Given this list of marker genes RPL15, RPS27, RPL30, MRPL19, RPS3, RPS15, RPS19, RPL4, RPL7, RPL23A, RPL14, RPS9, UBA52, RPS12, RPL38, RPS27A, RPS6KA1, RPS11, RPS10, RPL39, RPS14, RPSA, RPS21, RPS25, RPL18A, RPL29, RPL3, RPL27, RPL36 (NCBI Gene Id 92364), RPS15A, RPL13, RPL21, RPL13A, RPL23, RPS6KA2, RPS6KA6, RPS6, RPS26 (NCBI Gene Id 6231), RPL41, RPL10 (ribosomal protein L10), RPS23, RPL34, RPL12, RPS6KB2, RPL35A, RPLP0, RPS13, RPS29, RPL28, RPS4X, RPS4Y1 (ribosomal protein S4 Y-linked 1), RPS20, RPL11, RPL7A, RPL22, RPL37A, RPL37, RPL27A, RPS6KA3, RPL5, RPL9, RPS16, RPL10A, RPS8, RPL6 (NCBI Gene Id 6128), RPS5, RPL19, RPS6KB1, RPL3L, RPLP2, RPL31, RPL32, RPL24, RPS17, RPL8, FAU, RPS2, RPL36A, RPL17, RPS18, RPS24, RPS3A (NCBI Gene Id 6189), RPL35, RPS7, RPL18, RPL26, RPLP1, RPS28, here is a description of the gene set: studied in species Homo sapiens Human Gene Set: WP_CYTOPLASMIC_RIBOSOMAL_PROTEINS Cytoplasmic ribosomal proteins